Given this list of marker genes Itga2, Abca12, Itgb4, Psen2, Srf, Psen1, Errfi1, Ahdc1, Col1a1, Trp63, Wnt7a, Itga6, Vps33b, Cdsn, Col1a2, here is a description of the gene set: Mouse Gene Set: GOBP_SKIN_MORPHOGENESIS The process in which the anatomical structures of the skin are generated and organized. The skin is the external membranous integument of an animal. In vertebrates the skin generally consists of two layers, an outer nonsensitive and nonvascular epidermis (cuticle or skarfskin) composed of cells which are constantly growing and multiplying in the deeper, and being thrown off in the superficial layers, as well as an inner, sensitive and vascular dermis (cutis, corium or true skin) composed mostly of connective tissue. studied in species Mus musculus